The following is a description of a gene set: Human Gene Set: GOBP_BIOLOGICAL_PROCESS_INVOLVED_IN_INTERACTION_WITH_SYMBIONT studied in species Homo sapiens An interaction between two organisms living together in more or less intimate association. The term symbiont is used for the smaller (macro) of the two members of a symbiosis; the various forms of symbiosis include parasitism, commensalism and mutualism., and this is the list of marker genes: DCD, DEFB103A, DAO, GSDMB, NLRP6, DEFA5, PF4, MBL2, CTSG, ELANE, GPX1, LTF, POMC, HSPD1, ARG1, PLG, CYSRT1, CAMP, CFHR2, PCYOX1L, AZU1, MYD88, HRG, DEFB103B, ROMO1, TUSC2, DDB1, CFHR5, CXCL6, F2, APOL1, CFHR1, DEFA1B, SCNN1B, DEFA1, FN1, GAPDH, SPAG11B, DEFB130A, TREM1, F2RL1, NCF1